The following is a description of a gene set: part of: IRS-related events triggered by IGF1R; Insulin receptor signalling cascade Reactome Pathway: IRS-mediated signalling Release of phospho-IRS from the insulin receptor triggers a cascade of signalling events via PI3K, SOS, RAF and the MAP kinases. studied in species Homo sapiens, and this is the list of marker genes: TRIB3 (NCBI Gene Id 57761), AKT2, FLT3LG, PIK3R2, FGF4, KRAS, THEM4, PDPK1, FGF6, GRB2, TLR9, FGF10, FGF3, PIK3C3 (NCBI Gene Id 5289), FGF16, HRAS, FLT3 (NCBI Gene Id 2322), FGFR3, FGF19, GAB1, PTPN11, FGF17, SOS1, FGFR2, PDE3B, PIK3R4, PIK3R1, FRS2, FGF7, FGF5, FGF20, PIK3CB, FGF1, FGF9, KLB, FGF22, FGF23, NRAS, IRS1, FGF2, FGF8, IRS2, FGFR1, FGF18, PIK3CA, FGFR4 (fibroblast growth factor receptor 4), KL, GAB2